The following is a description of a gene set: A condition of not having consistently high levels of phenylalanine in the blood but of experiencing temporary hyperphenylalaninemia following ingestion of large quantities of phenylalanine (for instance, following an oral loading test with phenylalanine). species: Homo sapiens Human Gene Set: HP_TRANSIENT_HYPERPHENYLALANINEMIA Transient hyperphenylalaninemia, and this is the list of marker genes: SPR, PCBD1, IMPDH2, GCH1, NR4A2